The following is a description of a gene set: Any process that modulates the frequency, rate or extent of endoplasmic reticulum unfolded protein response. studied in species Mus musculus Mouse Gene Set: GOBP_REGULATION_OF_ENDOPLASMIC_RETICULUM_UNFOLDED_PROTEIN_RESPONSE, and this is the list of marker genes: Ufl1, Agr2, Pigbos1, Nck1 (non-catalytic region of tyrosine kinase adaptor protein 1), Wfs1, Abca7, Tmem33, Nck2, Dnajb9, Hspa5, Bfar, Akt1, Akt2, Atf6, Cops5, Crebrf (NCBI Gene Id 77128, CREB3 regulatory factor), Ddrgk1, Bok, Igtp, Ficd, Akt3, Xbp1, Pdia6, Pik3r1, Bax, Atf6b, Ptpn2 (protein tyrosine phosphatase, non-receptor type 2), Atad3a, Ern1, Bak1, Ptpn1